Given this list of marker genes Gad2, Lnx2, Csf1, Lrrn1, Recql, Eif2ak2, Upk1b, Zfp764, Adgrf5, Optc, Lclat1 (lysocardiolipin acyltransferase 1), Gm20172, Ilrun, Arc, Fign, Asb3, Zfp316, 9930111J21Rik1, Sox4, Bcat1, Tmem70, Slc24a2, Gabra4, Zdhhc17, Ppfia2, Cd300a, Syt13, Anxa4, Prrg3, Zfp839, Krt33b, Adgrl1, 5730507C01Rik, Zyg11b, Ncbp2, Cd3d, Sez6l, Serpinh1, Myocd, Gfap (glial fibrillary acidic protein), Acvr2a, Rgs9bp, Dennd1b, Dpt, Rbm7, Zfp462, Nipal4, Nfat5, Cflar, Ankrd13a, Tcp10a, Klk7, Sh3rf3, Myt1l, Ago2, Rph3a, Il17rd, Plxna4 (NCBI Gene Id 330281), Gcsam (NCBI Gene Id 14525), Abhd15, Lmx1a, Ucp1, Zfp236, Igf2bp3, Brinp1, Ccdc9b, Pramel3a, Shank3, Hrk, Or4e1, C130074G19Rik, Amotl1, Prim2, Lrtm2, Nf1, Cpeb3, Aplf, Cplx3, Uso1, Uts2b, Pdap1, Cbln3, Pramel3b, Kcnc4, Bmp3, Phf23, Lamtor3, Snai2 (NCBI Gene Id 20583), Atg2b, Syp, Agbl5, Ar, Bbip1, Srsf12, Klhl42, Lsamp, Pramel3c, Spon1, R3hdm2, Tti2, Rapgef1, Vav3, Sox14, Lmbr1, Ccdc65, Ankrd33b, Arhgap35, Nob1, Atxn7, D630023F18Rik, Ptbp2, Ebf1, Vps13a, Trpm3, here is a description of the gene set: from publication Chen Y, Wang X (PMID 31504780) species: Mus musculus Genes predicted to be targets of miRBase v22 microRNA mmu_miR_6950_3p in miRDB v6.0 with MirTarget v4 prediction scores > 80 (high confidence targets). Mouse Gene Set: MIR_6950_3P